Given this list of marker genes NTRK2, FYN, DOCK3, RAC1, BDNF, here is a description of the gene set: Reactome Pathway: NTRK2 activates RAC1 studied in species Homo sapiens DOCK3-mediated activation of RAC1 downstream of BDNF-induced signaling by NTRK2 (TRKB) plays a role in axonal growth and regeneration. DOCK3 can be recruited to the plasma membrane to activate RAC1 by binding to NTRK-associated FYN. Alternatively, DOCK3 can, upon poorly elucidated RHOG activation by the BDNF:NTRK2 complex, bind to the RHOG:GTP complex and activate RAC1 in an ELMO1-dependent manner. part of: Activated NTRK2 signals through FYN